The following is a description of a gene set: Any process that modulates the frequency, rate or extent of cellular response to transforming growth factor beta stimulus. species: Homo sapiens Human Gene Set: GOBP_REGULATION_OF_CELLULAR_RESPONSE_TO_TRANSFORMING_GROWTH_FACTOR_BETA_STIMULUS, and this is the list of marker genes: MIR15B (NCBI Gene Id 406949), VEPH1, MIRLET7G, FAM89B (family with sequence similarity 89 member B), HIPK2, LRG1 (NCBI Gene Id 116844), RNF111 (ring finger protein 111), PIN1, MIR323A, CAV3, HTRA1, MIR101-1, MIR93, SIRT1, MIR142, CFLAR, EMILIN1, CDKN2B, TP53, CAV2, MIR27B, ONECUT1, SMURF1, GOT1, BAMBI, ZNF703, SPRY2, ING1, XBP1, ITGA3, MIR302B, OGT, OVOL2, MIR361, STK11, FBN1, IL17F, CITED1, CREBBP, GDF15, LATS2, SPRED2, MIR199A1, CITED2, MYOCD, FBN2, MIR181A2, SINHCAF, FERMT1, CILP, HSPA1A, MIR106A, BRMS1, STRAP, MIR20A, ZBTB7A, DKK3, HTRA4, PPARG, BCL9L, FKBP1C, DLX1, SDCBP (NCBI Gene Id 6386), VASN, TRIM33, MIR204, HSPA5, SUDS3, MIR21, HSP90AB1, LTBP1, SNW1, MIR140, SKI, MECOM, PRDM16, LOX, MIR9-1, ZNF451 (NCBI Gene Id 80822), SPRED1, INTS9, AXIN1, MIR29B1, SMURF2, MIR342, FOLR1, SLC2A10, ZEB1, LTBP4, TET1, ING2, NREP, ENG, ASPN, ARID4B, SNX25, WFIKKN1, PPARA, MIR372, EP300, HDAC2, LATS1, PALS1, NRROS, FKBP1A, CIDEA, SMAD7, MIR145, RBBP7, SMAD2, PPM1A, USP15, SAP30, ZEB2, MIR18A, SOX11, BMP2, MIR30B, SAP130, MIR520C, WFIKKN2, MIR19B1 (microRNA 19b-1), ITGA8, MIR424, PDPK1, TGFB1I1, SMAD4, MIR498, IL17RD, NPNT, ADAM17, RASL11B, SMAD3, CHST11, NKX2-1, HTRA3, TWSG1, ONECUT2, RBBP4, MIRLET7F1, MTMR4, MIR564, MIR490, FLCN, CD109, GLG1, STUB1, BCL9, WNT1, TGFBR3L, ARID4A, MIR373, SMAD6, PBLD, MIR497, MIRLET7B, PEG10, SNX6, PMEPA1, TGFBR3 (NCBI Gene Id 7049), CDH3, MEN1, SPRED3, HDAC1, GIPC1, DAND5, MIRLET7A1, TSC22D1, MIR17, LEMD3, BRMS1L, SIN3A, MIR19A (microRNA 19a), IL4, SKIL, LDLRAD4, EID2, ADISSP (NCBI Gene Id 54976), ADAMTSL2, THBS1, MIR376C, CDKN1C, MIR98, LRRC32, SPRY1, SAP30L, SKOR2